Given this list of marker genes ELAVL4, NOL4L, TGOLN2, KCTD16, OTUD4, SESTD1, ESRRG, TBC1D8, TRIM59, ARHGEF12, NR2C2AP, PHF20, FAM161A, TRAK2, PIGA, ZNF804A, GLRX5, ADGRB3, SLC16A6, TMEM170A, B4GALT6, FAM234A, NME7, CANX, FAM43A, RGMA, KIF14, SRSF11, ACVR1, NCKIPSD, MTMR9, AGO1, PRKAA1, BAZ2B, GPATCH8, FEZ2 (NCBI Gene Id 9637), NEURL4, ITGA9 (NCBI Gene Id 3680), CERS6 (ceramide synthase 6), UBE2D3, CAND1, RC3H1, ATG14, MAFG, TMED7, HECW2, UCP3, SLC24A3 (NCBI Gene Id 96617), DICER1, ARFIP1, EPN2, MEOX2, VCF1, CYB5R4, EOGT, DOCK6, SNAP91, NPTX1, OSBPL11, CS, ATP2B4, F3, CLTA, CBLB, RNF38 (NCBI Gene Id 64796), SIX4, ABCB7, QKI (NCBI Gene Id 9444), ABCD3, TXNIP, PRKAG2, RALBP1, TEK, TGFB2, TNRC6C, LIPA, EPAS1, DYRK2, WDR47, TOMM70, PGRMC2, XPO4, MACIR, LYSMD2, ITGB8, PPP6R1, YWHAB, LRP2, BCL2L11, NHS, BTBD10, KLF6, RAB34, NRP1, ITSN2, USP32, TMEM266, ANXA4, CHD7, ATP11A, NPTN, SESN3, UHMK1, LBR, VPS37A, MRAS, CDK5R1, MITF (melanocyte inducing transcription factor), INHBB, SLC25A44, COL4A1, TNRC6A, CNTNAP3B, PDE1C, SECISBP2L, ENSG00000275993, FBN1, WNT10B, MMP13, VSIG1, BTBD3, FOXF1, CCDC6, KRT76, EPM2A, KMT2A, GAP43, S1PR1, TENT2, GPM6A, PRICKLE2, ARHGAP21, EFNB2, TMEM9B, ELAVL2, KIAA0232, LMTK2, EPS15, PPP1R10, SSR1, CEP55, NPEPL1, RTN4, ALCAM, E2F7, ADAM22, PRKCZ (protein kinase C zeta), SNN, POU3F2, MED12L, CDC14A, HOMER1, LDLR, KAT7, PPP1R9B, ZCCHC2, CHUK, DLG2, CNTN4, ITGA5, ARF4 (NCBI Gene Id 378), GRID2, CCDC141, NAT14, ROBO1, PNPLA6, ESR1, TBL1XR1, CDS1, A4GNT, PHACTR2, HOXC8, PRNP, AHDC1, MLLT6, ATXN1, ADCY2, USP31, IGFBP5, CELSR1, SLC2A1, ZNF821, SLC26A4, NCOA1, ARL6IP1 (ADP ribosylation factor like GTPase 6 interacting protein 1), KLF4, CIITA, STOX2, SYNJ1, CBLL1, NOL4, CLCN6, DDX6, BMP3, ING2 (NCBI Gene Id 3622), CFL2, EYA3, MLLT10, TGFA, LEPROTL1, GPRC5A (G protein-coupled receptor class C group 5 member A), KDM7A (lysine demethylase 7A), ZDHHC23, WNT1, OBI1, MNT, SOS2, CSF1, RICTOR, CAMSAP2 (calmodulin regulated spectrin associated protein family member 2), ADAMTS19, ABCA1, PLAA, WDFY4, GMFB, INO80, IL15, CDKN1B, DUSP1, ADAMTS15, ZBTB18, PHF3, ARL8B, NT5C3A, SCN9A, PEAK1, ZDHHC17, ADAM23, NFAT5, TMEM63B (transmembrane protein 63B), MOSPD1, ZDHHC7, PTGES3, FAM168B, SIRT7, ROCK1, CD72, ARRDC3, MXD1, ADAM10, CTSA, HBS1L, RBM24, ATP4B, SBF2, YTHDC2, USP33, CABP7, ATP6AP2, TMEM54, ATXN7L1, LTBP1, GTF2H1, ATP8A1, SNX27, RPS6KA5, MTMR10, ERBB3, MACROH2A1, CCT6A, CDKL5, DCP2, MMP15, RMND5A, SMS, MPL, UBE4B, AKAP1, SKIDA1, USP48, TGIF2 (TGFB induced factor homeobox 2), ADAM17, UBAP2L, SZRD1, BACH2, ZFYVE26, DENND4C (NCBI Gene Id 55667), AGFG1, RASSF8, KIAA1217, C1GALT1, DNMT1, RANGAP1, ARK2N, MAP3K9, GPCPD1, ANGEL2, PIGS (NCBI Gene Id 94005), DMXL1, NRARP, LRRC41, MTCL1, STARD13, MRGPRX3, MTMR14, CYTH3, PIK3C2A, ITPK1 (NCBI Gene Id 3705), MAP2K1, SGCB, MAFB, TANC1, NOG, RAB14, CDH20, VMP1, CADM1, WDR20, ADGRF5, CCKBR, CUL5, MIER1, AP4E1, PITPNM2, MMP10, GADD45A, B4GALT5, SESN2, GPR137C (NCBI Gene Id 283554), SPTY2D1, JMY, CASZ1, RFX7, FXR1, MDFIC, JARID2, BTAF1, BICC1, ERRFI1, ROBO2, RUNX2, CDK19, MAP3K4, SIK1, AGO4, KLF5, FMR1, MMD, here is a description of the gene set: Human Gene Set: MIR148B_3P Genes predicted to be targets of miRBase v22 microRNA hsa-miR-148b-3p in miRDB v6.0 with MirTarget v4 prediction scores > 80 (high confidence targets). species: Homo sapiens from publication Chen Y, Wang X (PMID 31504780)